The following is a description of a gene set: studied in species Homo sapiens Brain imaging abnormality Human Gene Set: HP_BRAIN_IMAGING_ABNORMALITY An anomaly of metabolism or structure of the brain identified by imaging., and this is the list of marker genes: SV2A, SNRPN, CHMP2B, IARS1, FBXO28, MT-TF, VPS33A, MT-ND5, KARS1, COG8, ACAT1, POLR1A (NCBI Gene Id 90784), EIF2AK3, MT-TH, RPIA, ASPA, PSEN1, SH2B1, WDR26, SYNGAP1, CREBBP, GAMT, APOE, MRPL39, TBCK, VCP, SLC25A12, COX11, GATM, POLRMT, LYRM4, CNP, SIM1, RAI1, TELO2, ATP10A, APC2, TREX1, NDUFB7, FOCAD, CACNA1G, MECR, SIN3B, SCN1A, IBA57, MT-CO2, DNM1L, PRNP, KMT2C (NCBI Gene Id 80260), UBE3A, MTHFR, TEFM, NF1, COQ4, COX16, ECHS1, SCYL2, SPRED1, EHMT1, TBL1XR1, MT-ND6, SIN3A (NCBI Gene Id 25942), GCSH, NGLY1, MT-CO1, SDHB, SLC6A1, NEXMIF, PIK3CA, ATP1A3, USP7, FOXP1, TUBG1, HSD17B10, PSEN2, BAP1 (NCBI Gene Id 8314), MT-ND1, FBXL4, NAT8L, GRM7, COL25A1, MT-TS2, PDE2A, SLC6A8 (NCBI Gene Id 6535), CHD2, PURA, PRRT2, ERGIC1, FDFT1, KCNQ3, CACNA1A, NIPA1, HMBS, LYRM7, ATN1, RERE, MPV17, ADORA2A, ALG12, MRPS34, SMARCE1, ATP1A2, SCN8A, DPAGT1, GALC, GFM2, TMEM106B, SUCLG1, PDP1, MT-TW, MT-ND4, MAPT, SMO, SMARCB1, LGI1, TRANK1, HMGCR, MT-CO3, PSAP, CYP27A1, COQ2, SQSTM1, HPDL, ABCD1, DHPS, PDGFB, SDHAF1, DEAF1 (DEAF1 transcription factor), ACP5, NAXE, LIPT2, TERT, MT-TQ, SUFU, SCN2A, EP300, AP2M1, NF2, SQOR (NCBI Gene Id 58472), GRN, TRAF7, SLC35A2, CACNG2, HTRA2, POLR3A, FARS2, VARS2, TREM2, SLC1A3, SDHD, SLC2A1, CDC42, NDUFAF6, RELN, AKT1, SLC39A8, DEPDC5, TUBB6, SATB2, NFU1, MAGEL2, ATAD3A, BTD, KCNQ2, MTRFR, NIPA2, MT-TL1, NSD1, DYRK1A, ALG1